The following is a description of a gene set: Genes up-regulated in comparison of control dendritic cells (DC) at 2 h versus those stimulated with LPS (TLR4 agonist) at 2 h. from publication Amit I, Garber M, Chevrier N, Leite AP, Donner Y, Eisenhaure T, Guttman M, Grenier JK, Li W, Zuk O, Schubert LA, Birditt B, Shay T, Goren A, Zhang X, Smith Z, Deering R, McDonald RC, Cabili M, Bernstein BE, Rinn JL, Meissner A, Root DE, Hacohen N, Regev A (PMID 19729616) mouse primary BMDCs were stimulated with tlr ligands and gene expression changes were profiled on Affymetrix arrays species: Homo sapiens Human Gene Set: GSE17721_CTRL_VS_LPS_2H_BMDC_UP, and this is the list of marker genes: POC5, TSPAN14, DHX30, RPL41, ELP3, NUDT3, SNX2 (sorting nexin 2), ACADS, BFAR, GPR146, ERLIN1, GPX4, DDX17, ZBP1, PLD1, MSN, EEF1B2, HTATIP2, PSMC3IP (PSMC3 interacting protein), ZIM3, MAD2L1BP, TIMELESS, ARL6IP1, CACFD1, SLC9A1, AAGAB, PTP4A2, SLC30A5, CPSF2, CDADC1 (cytidine and dCMP deaminase domain containing 1), PWP2, GATAD1, SDHAF2, CD177, CDT1, TFEB, TRIM34, SLC44A4, CCDC137, CRCP, MRC1, TMEM14C, NSMCE4A, BRCC3, NMU, UBP1, RBM10, ASGR2, SLC25A45, GTF2H4, NAXE, TSTD1, GP1BB, AKR1B10, ZBTB25, COA6, RPS14, PNPLA7, PIGS, MRPS15 (NCBI Gene Id 64960), DPM2, FAM53A, POLR3F, GNPAT, GPS1, FAF1, TPRKB, LPAR2, RGL2, RHOG, FERRY3, DOCK1, ARFGAP2, CPT2, DAD1, FBXO9, SEPTIN8, CCNE1, VDR, TMEM183A, MSL1, SLC39A13, PTDSS1, KTI12, SMIM8, QSER1, EPSTI1, CDC42SE1, SKP1, COQ9, FAM193B, DSTYK, ERCC3, NDUFS2, GRB10, CDCA7L, TAX1BP3, POLR2B, TADA1, AURKA, PEX2, DIS3, SMC3, CEACAM21, LIMD2, HEXB, MSH6, UNK, ICE2, GALT, SEC16A, MGAT2, MLYCD, RNF187, HAUS6, ZNF703, MED7, IHH, IFI30 (IFI30 lysosomal thiol reductase), IMPACT, MX2, RAB40C, SDHAF1, LSM3, ADIPOR1, TPRA1, CPEB1, TPK1, PPP1R17, TMEM186, NCKIPSD, ERCC6L, F11, MOCS2, ANKRD54, VPREB3, IRAK1, MED20, PEX13, TAF1C, HP, SLAMF9, MOGAT2, C7orf25, TMEM147, CLEC6A, FLOT2, DMAC1, STK38, GUSB, GNE, CYB5R1, P4HA2, SASH3, SLC26A2, PLAC8, CC2D1A, CCL11, ELOF1, PPM1G, ETNK1, PRMT3, RPL6, UQCC2, BCHE, PLEKHA2, GIT1, PGD, GRINA, TOPBP1, PAM16, NEPRO, ZNF106, KCNK13, STEAP1, TMUB2, SCAF8, MRPL44, LIAS, INTS14, BST2 (NCBI Gene Id 684), ELF2, SKI (SKI proto-oncogene), XPR1, TGFB3, KANSL2, MTA1, SWSAP1, HMGB3, MFAP1, PHF12, UBR7, TTI1, TAF10, PADI3, SETD4, ASF1B, ECRG4, URI1, ATG12